The following is a description of a gene set: Upregulation of HER2/ErbB2/Neu occurs in 15-30% of human breast cancers and correlates with poor prognosis. Identification of ErbB2/Neu transcriptional targets should facilitate development of novel therapeutic approaches. Development of breast cancer is a multistep process; thus, to identify the transcriptomes associated with different stages of progression of tumorigenesis, we compared expression profiles of mammary tumors and preneoplastic mammary tissue from MMTV-Neu transgenic mice to expression profiles of wild-type mammary glands using Affymetrix microarrays. We identified 324 candidate genes that were unique to ErbB2/Neu-induced tumors relative to normal mammary gland tissue from wild-type controls. Expression of a subset of these genes (82) was also changed in the preneoplastic mammary glands compared to wild-type controls, indicating that they may play a pivotal role during early events of ErbB2/Neu-initiated mammary tumorigenesis. Further analysis of the microarray data revealed that expression of several known transforming growth factor (TGF)-beta target genes was altered, suggesting that the TGF-beta signaling cascade is downregulated in ErbB2/Neu-induced tumors. Western blot analysis for TGF-beta-Receptor-I/ALK5 and immunohistochemistry for TGF-beta-Receptor-I/ALK5 and phosphorylated/activated Smad2 confirmed that the Smad-dependent TGF-beta signaling cascade was inactive in these tumors. Although absent in most of the tumor, phosphorylated Smad2 was present in the periphery of tumors. Interestingly, presence of phosphorylated/activated Smad2 correlated with expression of Activin-Receptor-IB/ALK4, suggesting that although Smad-dependent TGF-beta signaling is absent in ErbB2/Neu-induced tumors, Activin signaling may be active at the leading edge of these tumors. Cumulatively, these data indicate that the TGF-beta pathway is intrinsically suppressed in ErbB2/Neu tumors via a mechanism involving loss of TGF-beta-Receptor-I/ALK5. Mouse Gene Set: LANDIS_ERBB2_BREAST_TUMORS_324_UP Up-regulated genes from the genes identified by two analytical methods as changed in the mammary tumors induced by transgenic expression of ERBB2. species: Mus musculus from publication Landis MD, Seachrist DD, Montañez-Wiscovich ME, Danielpour D, Keri RA (PMID 15897883), and this is the list of marker genes: Ss18l2, Crybg1, Traf4, Xbp1, Ctnnd1, F11r, Acsl4, Dok1, Ier3, Inppl1, Arhgef5, Ndst1, Frrs1, Homer2, Clic1, Pitpnc1, Nucb2, Galnt3, Knop1, Fhdc1, Tpd52, Atp6v1e1, Ppp1cb, Ccnd1, Dap, Tfap2c, Serp1, Dusp6, Unc119b, Sptan1, Irx3, Cmas, Cldn7, Ormdl2, Itpr2, Mlh1, Litaf, Cyb561, Ezr, Ank3, Smagp (NCBI Gene Id 207818), Igf2r, Ptpn2, Mapk8ip1, Cxcl1, Ctsc, Mien1, Csrp1, Slc29a1, Cd82, Rcn2, Atp6ap2, Rrm2, Ell2, Shroom3, Tmed3, Skp1, Cdk1, Timd2, Perp (PERP, TP53 apoptosis effector), Vdr, Slc66a2, Slain1, Cradd, Ppp3ca, Tceal9, Dck, Ctbp2, Krt8, Etnk1, Aldoc, Chek1, Fxyd3, Tgfa, Psapl1, Cystm1, Flnb, Ank, Id2, Lig3, Fut8, Etv1, Chmp2b, Slc12a2, Plet1, Actn4, Fgd1, Lxn, Mydgf, Bag2, Dsg2, Lrrfip1, Tuft1, Rtkn, Sox4, Xist, Papss1 (NCBI Gene Id 99599), Wee1, Ehf, Socs2, Rab10, Pdia4, Flvcr2, Npnt, Wnk2, Enah, Cd9, B4galt6, Calm2, Ebp, Abracl, St3gal5, 4931406C07Rik, Fbxw7, Kcnn4, Erbb3, Epcam, Lsr, Srp19, Tspan8 (tetraspanin 8), Golph3, Zc3h15, Naxe, St6galnac4, Wfdc18, Irf6, Nr4a1, Ier2, Cip2a, Tiam1, Errfi1, Tpd52l1, Stk39, Lcn2, Rnf149, Cldn3, Mob1b, Rab18, Lman1, Lmo4, Wwc1, Strbp, Akap12, Retreg1, Tom1l1, Ptk7, Wsb2, Serinc3, Ddx6, Spint1, Atp6v1a, F3